The following is a description of a gene set: Mouse Gene Set: chr6A3 studied in species Mus musculus, and this is the list of marker genes: Aass, Gm13781, Mir182, Gm8945, Gm13717, Rnf133, Exoc4, Hyal6, Gpr37, Gm5989, Rnf148, 1700095J07Rik, Ptprz1, Tspan12, Gm25589, Lrrc4, Gm13850, Gm42573, Gm20706, Gm8930, Klhdc10, Klf14, Plxna4 (plexin A4), Cpa1, Cep41, Gm13853, Zc3hc1, Ube2h, 1700012C14Rik, Asb15, Tnpo3, Mir592, Pot1a, Gm13782, Tas2r118, Lep, Gm1401, Spmip1, Irf5 (NCBI Gene Id 27056), Iqub, Ndufa5, Gm5303, Gm5302, Snd1, Gm20756, Gm22529, Plxna4os1, Pax4, Spam1, Cped1, Flnc, Chchd3, Slc13a1, 4930528J11Rik, Gm18327, Gm22321, Gm6117, Smkr-ps, Smo (smoothened, frizzled class receptor), Strip2, Impdh1, Kcp, Gm13724 (predicted gene 13724), Mir29a, Lmod2, Gm8950, Cpa2, Cpa4, 6530409C15Rik, Cadps2 (NCBI Gene Id 320405), Gm5301, Mest, 5330437M03Rik, 2210408F21Rik, Gm24691, Grm8, Zfp800, Mir129-1, 1700012A03Rik, Tmem209, Gm13835, Gcc1 (NCBI Gene Id 74375), Wnt16, Gm26021, Mkln1os, Gm26627, Podxl, C130093G08Rik, Ssmem1, Copg2, Fam3c, Cpa5, Mir96, Lrguk, Ing3, 4930412F09Rik, Hilpda, BC049739, Rbm28, Gm6719, Opn1sw, Hyal5, Tmem229a, Garin1a, Gm22267, Gm3289, Nrf1, Gm13855, Atp6v1f, Mir183, Ahcyl2, Wasl, Hyal4, Garin1b, Plxna4os2, 5330406M23Rik, Gm24443, Prrt4, Gm18861, Mir335, Mir29b-1, Gm30270, Tsga13, Lncpint, Arf5, Tspan33, Fezf1, Calu, Gm13856, Gm13848, Slc35b4, Gm24536, Gm13854, Gm26310, Gm8927, Mkln1, Gm3294, Fscn3, Ccdc136